The following is a description of a gene set: Leptin-insulin signaling overlap studied in species Mus musculus Mouse Gene Set: WP_LEPTININSULIN_SIGNALING_OVERLAP, and this is the list of marker genes: Jak2, Socs2, Lepr, Irs1, Irs2, Akt1, Insr (insulin receptor), Ins1, Irs4, Stat3, Lep, Socs1, Socs3, Pdpk1, Dgkz, Pik3cg, Pik3r3, Irs3